The following is a description of a gene set: studied in species Homo sapiens A partial dislocation of the atlantoaxial joints. C1-C2 subluxation Human Gene Set: HP_C1_C2_SUBLUXATION, and this is the list of marker genes: DDR2, COL2A1, ARSL, MMP2, MADD, GNPTAB, IDUA